Given this list of marker genes Psmb3, Nsun2, Set, Creld2, Srsf7, Ranbp1, Prdx1, Pid1, Cotl1, Ehd1, Ybx3, Adam8, G3bp1, BC005537, Morf4l2, Pebp1, Atp8b4, Hspe1, Lgals3, Fn1, Myh9, Arpc1b, Rab32, Calr, Eif4g2, Cfl1, Cd68, Msr1, Actg1, Glrx, Vcan, Eif2s3x, Znhit1, Cct3, Tpm3 (tropomyosin 3, gamma), Emp3, Nme1, Srsf2, Rbpj, Nolc1, BC031181, Cggbp1, Aprt, Kras, Card19, Cebpz, Gas7, Emilin2, Niban2, Tagln2, Capg (capping actin protein, gelsolin like), Llph, Hnrnpm, Eif4a1, Pfn1, Pilra, Adprh, Eif3a, Pdia6, Tpm4, Ninj1, Atp5mc1, Capn2, Dok2, Ralb (v-ral simian leukemia viral oncogene B), Cd44, Gda, Eif2s1, Anxa2, Ebna1bp2, Ctsz (cathepsin Z), Mydgf, Pkm, Itgam, Slc11a1, Snrpa, Bop1, Ybx1, Ftl1, Vim, Cstb, Snrpd1, Flna (filamin, alpha), Naa15, F13a1, Gapdh, Ezr, Lgals1, Rnf126, Mrps15, Hspa9, Nab2, Ahnak, Anp32b, Ctsd, Calm1, Ppp1r14b (protein phosphatase 1, regulatory inhibitor subunit 14B), Bak1, Psmb6, Hsd17b12, here is a description of the gene set: studied in species Mus musculus Mouse Gene Set: CUI_MONOCYTE_M_CSF_RESPONSE_UP Cytokines mediate cell-cell communication in the immune system and represent important therapeutic targets. A myriad of studies have highlighted their central role in immune function, yet we lack a global view of the cellular responses of each immune cell type to each cytokine. To address this gap, the authors created the Immune Dictionary, a compendium of single-cell transcriptomic profiles of more than 17 immune cell types in response to each of 86 cytokines (>1,400 cytokine-cell type combinations) in mouse lymph nodes in vivo. A cytokine-centric view of the dictionary revealed that most cytokines induce highly cell-type-specific responses. For example, the inflammatory cytokine interleukin-1β induces distinct gene programmes in almost every cell type. A cell-type-centric view of the dictionary identified more than 66 cytokine-driven cellular polarization states across immune cell types, including previously uncharacterized states such as an interleukin-18-induced polyfunctional natural killer cell state. from publication Cui A, Huang T, Li S, Ma A, Pérez JL, Sander C, Keskin DB, Wu CJ, Fraenkel E, Hacohen N (PMID 38057668) Genes positively differentially expressed in cell type: Monocyte upon treatment with cytokine: M-CSF in mouse lymph nodes in vivo.